The following is a description of a gene set: Mouse Gene Set: REACTOME_FORMATION_OF_THE_NON_CANONICAL_BAF_NCBAF_COMPLEX studied in species Mus musculus Formation of the non-canonical BAF (ncBAF) complex, and this is the list of marker genes: Smarcd2, Bcl7b, Bcl7a, Smarca4, Smarcc1, Ss18 (SS18, subunit of BAF chromatin remodeling complex), Smarcd3, Bcl7c, Actl6a (actin-like 6A, NCBI Gene Id 99742), Smarcd1, Ss18l1, Bicral, Actb, Brd9, Bicra, Smarcc2